The following is a description of a gene set: Once in the nucleus, beta-catenin is recruited to WNT target genes through interaction with TCF/LEF transcription factors. This family, which consists of TCF7 (also known as TCF1), TCF7L1 (also known as TCF3), TCF7L2 (also known as TCF4) and TCF7L3 (also known as LEF1), are HMG-containing transcription factors that bind to the WNT responsive elements in target gene promoters. In the absence of WNT signal, TCF/LEF proteins recruit Groucho/TLE repressors to inhibit transcription; upon WNT stimulation, beta-catenin can displace Groucho/TLE from TCF/LEF proteins to initiate transcriptional activation. Although this model for WNT-dependent activation of target genes is widely accepted, it is important to note that TCF/LEF proteins are not redundant and can contribute to WNT target gene expression in a number of different ways. In particular, TCF7L1 (TCF3) is thought to have a more pronounced repressor function than other TCF/LEF family members. A couple of recent studies in Xenopus and mammalian cells show that WNT- and beta-catenin-dependent phosphorylation of TCF7L1(TCF3) promotes its dissociation from the promoter of target genes and allows gene expression through relief of this repression activity.<br><br><br>The role of beta-catenin at WNT promoters hinges upon its ability to act as a scaffold for the recruitment of other proteins. The structure of beta-catenin consists of 12 imperfect ARM repeats (R1-12) flanked by an N-terminal and C-terminal extension (NTD and CTD respectively), with a conserved Helix C located between R12 and the CTD. Nuclear beta-catenin interacts with TCF/LEF at WNT target genes through ARM domains 3-9. The N and the C terminal regions are important for the recruitment of transcriptional activator and repressors that contribute to WNT target gene expression. The N-terminal ARM domains 1-4 recruit the WNT-pathway specific activators BCL9:PYGO while the C-terminal region (R11-CTD) interacts with a wide range of general transcriptional activators that are involved in chromatin remodelling and transcription initiation. These include HATs such as P300, CBP and TIP60, histone methyltransferases such as MLL1 and 2, SWI/SNF factors BRG1 and ISWI and components of the PAF complex. Although many binding partners have been identified for the C-terminal region of beta-catenin, in many cases the timing and relationship of these interactions and indeed, the exact complex composition remains to be elucidated. Moreover, because many of the interacting partners appear to bind to overlapping regions of beta-catenin, it is unlikely that they all bind simultaneously. For simplicity, the interactions have been depicted as though they occur independently of one another; more accurately they are likely to cycle successively on and off beta-catenin to promote an active chromatin structure. Reactome Pathway: Formation of the beta-catenin:TCF transactivating complex part of: TCF dependent signaling in response to WNT studied in species Homo sapiens, and this is the list of marker genes: H3C15, H2AC14, H2BC26, TRRAP, H3-4, H2BC12L, BCL9, H2AC20, TERT, H2BC11, TCF7L1, DPY30, BCL9L, H2AC18, MEN1, H2BC13, CTNNB1, TCF4, H4C1, LEF1, MYC, H2BC21, H2AX, H2AJ, H2AZ2, PYGO1, RBBP5, H2AC4, H2BC17, TCF7, WDR5, TLE1, H2BC1, KAT5, H3-3A, RUVBL1, H2BC14, H2BC5, TLE3, H3C1, EP300, CREBBP, H2BC12, HDAC1, KMT2B, H2BC9, RUNX3 (RUNX family transcription factor 3), H2BC3, H2BC15, H2BC4, TLE4, TLE2, TCF7L2, ASH2L, LEO1, H2AB1, AXIN2, SMARCA4, CDC73, H2AC7, H2AC6, PYGO2